Given this list of marker genes CLIP1, DELE1, MTURN, USB1, PNOC, FYB1, JPT2, MTMR1, SMS, ZNF205, CSF2, ETF1, USP8, UNC119, ARHGAP18, COMMD4, WDR43, AHSA1, ENO3, GRB2, SEC62, BHLHE40, ERG28, NOL6, HEATR3, BAX, KPTN, AGPAT3, PRF1, SAAL1, RUVBL2, FGF13, CYP51A1 (cytochrome P450 family 51 subfamily A member 1), NAB2, ACP6, AATF, IFNAR1, FAM98C, RBIS, PRDX3, KDM5B, STAT4, TMEM229B, PSENEN, ZCCHC9, TMC8, EXOC3, ME2, MFSD14B (major facilitator superfamily domain containing 14B), FAS, PFDN1, AIP (aryl hydrocarbon receptor interacting protein), METRN, PRXL2A, NPEPL1 (aminopeptidase like 1), NOL11, THEM5, TTPAL, KYAT1 (NCBI Gene Id 883), SUPT3H, TRAPPC4, FAM120B, VPS18, CHCHD1, ERH, NDUFA11, PCDHA12, MPDU1, ETFB (NCBI Gene Id 2109), SGMS1, TWSG1 (NCBI Gene Id 57045), DHX36, KSR1 (kinase suppressor of ras 1), ATP5MG, IP6K1, PSMB1, SLC35B2, ELF4, NDUFA7, MLLT6, CREBZF, GIGYF2, ARHGAP20, GPR65, MBD3, BCL2A1, ABCG1, DDX41, PRAF2, EIF3B, TBCEL, GABARAPL2, COMMD3, TTC38, PPP3CC, POLL, AK2, HAUS2, GIGYF1, HVCN1, SYNJ2BP, COPS2, TIMM10B, SCAPER, DMAC2, EXOSC5, TRIM13, ESYT2, PDCD11, ITGAE, SELENOK, TRAPPC14, RSPRY1, SEC24B, RPS6KB2, WIPI1, DNAJB11, APTX, NOL8, YPEL3, SUSD1, PPIE, TDP1, CAPNS1, ZDHHC21, GNG2, HACD3, GPR171, JARID2, SLC35F2, HIGD2A, YRDC, VDAC3, INTS8, ARHGEF2, ULBP1, NOC2L, FDXR, PGM2, OXR1, SLC5A4, CDK7, MANF, SIGMAR1, TMEM123, MED22 (NCBI Gene Id 90955), CISD3, ENSG00000286190, KIAA0040, APPBP2, XXYLT1, VAT1L, RHBDD3, ALDH16A1, CCDC71, FADS6, GALNT10, ZMAT5, EML2, GPAA1, DUSP6, MRPL19, TRAT1, FAM178B, COMMD6, SRPK2, NR2C2AP, FIBP, LSM4, PIK3C3, MRPS18A, GSDMD, ELF2, KCNJ4, IRF4, SIK3, CCR8, NET1, ZCCHC12, CTSD, DUSP9, TPST2, NOB1, ESF1, HARBI1, BRIX1, BIRC6, RBM48, DYNC1LI1, HDAC3, ACVR1B, TTLL5, YME1L1, MACO1, NFKBIL1, FBXL6, AKT1S1, ITPRIP, GTF2H2, here is a description of the gene set: from publication Borjesson DL, Kobayashi SD, Whitney AR, Voyich JM, Argue CM, Deleo FR (PMID 15879137) Human Gene Set: GSE2405_S_AUREUS_VS_UNTREATED_NEUTROPHIL_UP Polymorphonuclear leukocytes (PMNs) were obtained from healthy individuals in accordance with protocols approved by the Institutional Review Board for Human Subjects at the University of Minnesota and the National Institute of Allergy and Infectious Diseases. PMNs (107) were combined on ice with live S. aureus (108) or with live or heat-killed A. phagocytophilum (bacteria isolated from 5x106 infected HL60 cells for a ratio of 1 infected HL60 cell: 2 PMNs, ~ 5-20 A. phagocytophilum: PMN) in wells of a 12-well tissue culture plate (pre-coated with 20% autologous normal human serum). Unstimulated control assays received either buffer (for S. aureus comparisons) or clarified HL60 lysate (for A. phagocytophilum comparisons). Plates were centrifuged at 350 x g for 8 min at 4oC to synchronize phagocytosis and incubated at 37 deg. C in a CO2 incubator for the indicated times. At the indicated times, tissue culture medium was aspirated from the plate and PMNs were lysed directly with RLT buffer (Qiagen, Valencia, CA). Purification of PMN RNA and subsequent preparation of labeled cRNA target was performed as described in Methods. Labeling of samples, hybridization of cRNA with HU133A oligonucleotide arrays (Affymetrix, Santa Clara, CA), and scanning were performed according to standard Affymetrix protocols ( http://www.affymetrix.com/pdf/expression_manual.pdf ). Experiments were performed in triplicate, using PMNs from three healthy individuals for each treatment. Genes up-regulated in polymorphonuclear leukocytes (9h): S. aureus infection versus control. species: Homo sapiens